Given this list of marker genes PPP1R14C, OSER1, COX5B, CDH1, ACSL1, AKR1B10, ZNF165, SETD6, KRT5, SPINT1, KLK5, RTKN, SPINT2, CRYBG1, SH2D3A, ENTPD2, ELF3, ELMO3, TLCD1, SCNN1A, PRSS8, KLK6, GAREM1, FGFBP1, FOSB, TC2N, MAF, LCN2, MUC1, PRRG4, GSN, GJB3, ST14, PROM2, MAL2, MYO5B, RNF144B, DRAM2, RNF43, TSTD1, PTPN6, TSC22D3, BLNK, PDZK1IP1, EPN3, EPHA1, DSG3, PRR15L, SYTL1, NHSL3, TACSTD2, RHOD, HOOK2, RBL2, DMAC1, CKMT1B, BSPRY, RNF39, CDH3, SERPINA3, S100A14, C6orf132 (NCBI Gene Id 652183), ESRP1, CDS1, SUSD6, TMEM183A, MBNL3, RAB25, SLC11A2, TRIM29, APRT, S100P, IRF6, LAD1, CCNL1, EPB41L4A, TMEM191A, TMEM87A, LITAF, ITPA, SLC49A4, MPZL3, PKP3, TMEM30B (NCBI Gene Id 161291), MACC1, ITGB6 (integrin subunit beta 6), ADGRF1, PPL, C1orf116, MPP7, TMEM134, LIMK2, FXYD3, KRT15, F11R, CD24, ELF1, SLPI, STEAP4, ESRP2, EMC10 (NCBI Gene Id 284361), MARVELD2, KCNK1, KRT16, CD24P4, DUSP16, CLCA2, DMKN, SPINT1-AS1, MIR205, ATP1A1, FAM83B, GRHL2, EHF, SH3YL1, KIAA0040, GRAMD2A, SKIC8, CD24P2, OVOL2, SSH3, ZFP36, CBLC, MRFAP1L2, S100A8, OVOL1 (ovo like transcriptional repressor 1), here is a description of the gene set: A better molecular characterization of breast cell lines (BCL) may help discover new markers to apply to tumour samples. We performed gene and protein expression profiling of 31 BCL using whole-genome DNA microarrays and immunohistochemistry (IHC) on 'cell microarrays' (CMA), respectively. Global hierarchical clustering discriminated two groups of BCL: group I corresponded to luminal cell lines, group II to basal and mesenchymal cell lines. Correlations with centroids calculated from a published 'intrinsic 500-gene set' assigned 15 cell lines as luminal, eight as basal and four as mesenchymal. A set of genes was differentially expressed between basal and luminal samples. Mesenchymal and basal subtypes were rather similar and discriminated by only genes. The expression of 10 proteins (CAV1, CD44, EGFR, MET, ETS1, GATA3, luminal cytokeratin CK19, basal cytokeratin CK5/6, CD10, and ERM protein moesin) encoded by luminal vs basal discriminator genes confirmed the subtype classification and the validity of the identified markers. Our BCL basal/luminal signature correctly re-classified the published series of tumour samples that originally served to identify the molecular subtypes, suggesting that the identified markers should be useful for tumour classification and might represent promising targets for disease management. Human Gene Set: CHARAFE_BREAST_CANCER_BASAL_VS_MESENCHYMAL_UP from publication Charafe-Jauffret E, Ginestier C, Monville F, Finetti P, Adélaïde J, Cervera N, Fekairi S, Xerri L, Jacquemier J, Birnbaum D, Bertucci F (PMID 16288205) Genes up-regulated in basal-like breast cancer cell lines as compared to the mesenchymal-like ones. species: Homo sapiens